The following is a description of a gene set: Chronic furunculosis species: Homo sapiens A furuncle (boil) is a skin infection involving an entire hair follicle and nearby skin tissue. Chronic furunculosis refers to recurrent episodes of furuncles, often caused by recurrent staphylococcus infection. Human Gene Set: HP_CHRONIC_FURUNCULOSIS, and this is the list of marker genes: IL17RA, OTULIN, PSEN1, CTSC, PSENEN